The following is a description of a gene set: Binding to an hormone, a naturally occurring substance secreted by specialized cells that affect the metabolism or behavior of cells possessing functional receptors for the hormone. Hormones may be produced by the same, or different, cell as express the receptor. Mouse Gene Set: GOMF_HORMONE_BINDING studied in species Mus musculus, and this is the list of marker genes: Thrb, Gper1, Crhbp, Ghsr, Lepr (NCBI Gene Id 16847), Ghr (growth hormone receptor), Galr3, Ar, Fshr, Aldh1a3, Ucn2, Gcgr, Cmklr1, Gipr, Insr, Hcrtr1, Atp1a2, Rnls, Prlr, Sult2b1, Thra, Pkm, Ednrb, Adrb3, Galr1, Cmklr2, Pth2r, Oxtr, Serpina7, Calr, Hcrtr2, Adra2a, Adra2b, Adcyap1r1, Calcr, Adra2c, Shc1, Sec61b, Vipr2, Cckar, Glp2r, Glp1r, Ghrhr, Cdh13 (cadherin 13), Nr3c1, Mchr1, Ramp2, Tspo, Inhba, Sctr, Ttr, Pgr, Atp1a1 (NCBI Gene Id 229653), Slc40a1, Crhr1, Lhcgr, Npr1, Cckbr, Mc4r, Crym, Prlhr, Adipor1, Igf1r, Ctsh, Mc3r, Sec61bl, Mc5r, Slc39a9, Esr2, C2cd2l, Mtnr1a, Crhr2, Npr3, Mc1r, Pde3a, Rxfp1, Galr2, Vipr1, Lrp2, Egfr, Abhd2, Calcrl, Il23r, Adipor2, Amhr2, Rxfp2, Avpr1a, Esr1, Ramp1, Ide, Hk3, Pik3r1, Anxa5, Npr2, Drd4, Pth1r